The following is a description of a gene set: studied in species Mus musculus Mouse Gene Set: GOBP_DENTATE_GYRUS_DEVELOPMENT The process whose specific outcome is the progression of the dentate gyrus over time, from its formation to the mature structure. The dentate gyrus is one of two interlocking gyri of the hippocampus. It contains granule cells, which project to the pyramidal cells and interneurons of the CA3 region of the ammon gyrus., and this is the list of marker genes: Bloc1s6, Pomt2, Reln, Kif3a, Prox1 (prospero homeobox 1), Neurod1 (NCBI Gene Id 18012), Pianp, Kcnq2, Btg2, Pomgnt1, Emx2, Lef1, Mdk, Vps13b, Neurod6, Fxr1, Csf1r, Fezf2, Atat1, Tuba1a, Pten, Sct, Smo, Fbxo41, Drd1, Scn2a, Tmem108, Nr2e1, Lmx1a, Large1, Fxr2